The following is a description of a gene set: Human Gene Set: GSE7568_CTRL_VS_3H_TGFB_TREATED_MACROPHAGES_WITH_IL4_AND_DEXAMETHASONE_DN Genes down-regulated in macrophages differentiated in the presence of IL4 and dexamethasone for 5 days versus those subsequently treated with TGFB1 for 3h. studied in species Homo sapiens from publication Gratchev A, Kzhyshkowska J, Kannookadan S, Ochsenreiter M, Popova A, Yu X, Mamidi S, Stonehouse-Usselmann E, Muller-Molinet I, Gooi L, Goerdt S (PMID 18453574) The goal of the study was to identify the effects of TGF-beta on primary human macrophages maturated under different conditions., and this is the list of marker genes: CXCR6, ZDHHC9, PHLPP1, PLXNA1, NUP214, FBXW7, SPP1, CHD3, FBXO28, PKD1, ZMYM5, TMEM86B, RNPEPL1, ATG2B, CETN2, STAU1, ANKRD13C, KLF12, HIPK1 (NCBI Gene Id 23323), TAGLN2, ZNF318, CCNB1IP1, RB1CC1, MAP3K3, RO60, NEMP2, PDCL, VPS50, RAB23, RFX7, GOLGA3, MACF1, ACTR1A, MBTPS1, WDR76, SGF29, FLNA, STAT3, RICTOR, ACBD4, CEP95, ZIK1, SIK3, TECPR1, PLCG1, PTAR1, ECPAS, CLDND1, HAUS6, EXD2, GCC2, SF1, CHD8, SLC25A27, BRD3, RPRD1A, WDSUB1, PHF2, NF2, METTL8, EEIG1, PDE4B, PSME4, PPP2R2A, GMPR2, SVIL, TCF7, OLFML3, TMEM67, SYT17, BLOC1S5, PARN, DYRK1A, RPRD2, ANKRD49, ZFR, CRY2, RTN4, ATG5, C2CD2, USP4, CNNM3, DNAI4, IFT52 (NCBI Gene Id 51098), ATG4C, PIGM, EPS15, ROCK2, ACTR8, ZAN, MTR, PRKX, IL6R (interleukin 6 receptor), LRRC66, RBM27, CSK, CAMSAP1, USP22, TNFRSF14, TLR6, MANEA, CORO1C, PHF20L1, HIPK3, AKAP10, HUS1, SPHK2, YTHDC2, CARNS1, NISCH, SERINC1 (serine incorporator 1), FBXO45, MGAT5, RNF25, ANKLE2, ERCC6, CDKAL1, MSI2, RFLNB, DCUN1D4, STRIP1, TIA1, CERS6, TMEM63B, GABRA4, ZDHHC4, ATP13A3, SLC35E1, SLAMF6, BCOR, TCP11L2, RNGTT, STAR, ANAPC4, PRDM9, B3GALT2, PRKAR2B, LIN9, TGFBR3, ANKRD28, TNRC6A, PDE4D, NRBP2, BRF1, UHMK1, SKIC3 (NCBI Gene Id 9652), PARP6, AP3B1, PANK2, RFX1, PABIR1, CDK16, SLC35E3, AP1AR, SYDE2, HEXB, C2orf42, RNF103, DRAM2, EHMT2, NAA16, ARHGAP26, YPEL5, RIPOR2, RBM33, PMAIP1, MRPL4